The following is a description of a gene set: from publication Chen Y, Wang X (PMID 31504780) species: Mus musculus Mouse Gene Set: MIR_12190_3P Genes predicted to be targets of miRBase v22 microRNA mmu_miR_12190_3p in miRDB v6.0 with MirTarget v4 prediction scores > 80 (high confidence targets)., and this is the list of marker genes: Zc3h7b, Tnrc6b, Pnoc, Ing4, Fam163a, Gins3, Zfp871, Ddx41, Mical3, Hoxc10, Lipm, Ddx19a, Il13ra1, Lhfpl6, Isg20, Csf1, Nova1, Tmem45a2, Klhl5, Dnase2b, Septin1, Zfp444, Cyp2b9, Aldh6a1, Pdgfa, Npas4, Srl, Gspt1, Tmem123, Btf3l4, Ms4a6c, Col4a3, Sstr1, Prdm15, Iftap, Rbmyf9, Hycc1, Rbmyf1, Rbpms2, Cd300lb, Sp4, Krtap4-1, Rnf11, Nsa2, Clec4e, Ces2g, Rbmy, Shox2, Tcf12, Pim2, Cntnap2, Krtap2-4, Nkiras1, Med1, Thrb, Rac2, Nufip2 (NCBI Gene Id 78671), Ablim1, Dlg1, Irak2, Zfp182, Sertad4, Capza2, Sacm1l (NCBI Gene Id 83493), Tbc1d4, Phf11b, Cers6, Phf11c, Scamp1, Tmem106a, Vamp1, Lipa, Hat1, Rbmyf5, Kirrel3, Amdhd1, Dlst, Zdhhc9, Lce1e, Lims1, Alg9, Fshb, Tmem255a, Parp14, Rbmyf7, Rbmyf2, Ube2w, Grtp1, Spry2, Ly6e, Zkscan8, Trim66, Xbp1, Elmod2, Rab11fip1, Rbmyf8, Naaladl2, Ogg1, Hoxd13, Zmat1, Rbmyf3, Zfand5, Psmd3, Gnb4, Fnbp4, Copb2, Lmf2, Oprk1, Pik3cb, Igsf9b, Trak1, Caprin1, Rap1a, Gab3 (growth factor receptor bound protein 2-associated protein 3), Impact, Rbmyf6, Phf11d, Ythdc1 (YTH domain containing 1), Serpinb9c, Nat1, Ap1s3, Greb1l, Arpp21 (cyclic AMP-regulated phosphoprotein, 21), Phf11a (PHD finger protein 11A)